The following is a description of a gene set: Mouse Gene Set: WP_WHITE_FAT_CELL_DIFFERENTIATION species: Mus musculus White fat cell differentiation, and this is the list of marker genes: Ddit3, Klf5, Gata3, Nr1h3, Gata2, Ins1, Klf15, Irf3, Wnt10b, Ebf1, Rara, Egr2, Klf4, Creb1, Tle3, Cebpd, Nr2f2, Ctnna1, Nr3c1, Foxo1, Cebpa, Tcf7l1, Srebf1, Irf4, Cebpb, Zfp423, Stat5a, Pparg, Klf2, Mecom, Stat5b, Rora